The following is a description of a gene set: species: Homo sapiens Genes in the cancer module 42. Human Gene Set: MODULE_42, and this is the list of marker genes: NDUFB10, NDUFS5, NDUFA4, NDUFS8 (NCBI Gene Id 4728), NDUFV2, NDUFA5, NDUFS4, NDUFB8, NDUFB5, NDUFS3, NDUFA6, NDUFA3, NDUFA9, NDUFA2, NDUFS6, NDUFV1, NDUFS1, NDUFAB1, NDUFB3, NDUFB7, NDUFB1, NDUFC1, NDUFS2, NDUFA7, NDUFA1